Given this list of marker genes RHAG, RHD, EPB42, SPTB, SPTA1, ANK1 (NCBI Gene Id 286), SLC4A1, RHCE, here is a description of the gene set: Spherocytosis The presence of erythrocytes that are sphere-shaped. Human Gene Set: HP_SPHEROCYTOSIS species: Homo sapiens